The following is a description of a gene set: studied in species Homo sapiens The process whose specific outcome is the progression of vasculature of the renal system over time, from its formation to the mature structure. Human Gene Set: GOBP_RENAL_SYSTEM_VASCULATURE_DEVELOPMENT, and this is the list of marker genes: PDGFD, PKD2, WT1, BMP7, MIR125A, EDNRA, FOXC2, IL6R, ITGB3, EGR1, PDGFB, BMP4, CD34, TCF21, NOTCH3, PECAM1, AQP1 (aquaporin 1 (Colton blood group)), CFLAR, HES1, ANGPT2, ACTA2, ANGPT1, PDGFRB, NRP1, NOTCH1, PDGFRA, NOTCH2, EDN1, TEK, GPR4, PDGFA, SERPINB7, OSR1